The following is a description of a gene set: The directed movement of zinc (Zn II) ions into, out of or within a cell, or between cells, by means of some agent such as a transporter or pore. studied in species Homo sapiens Human Gene Set: GOBP_ZINC_ION_TRANSPORT, and this is the list of marker genes: TRPM2, SLC30A6, SLC30A10, SLC39A12, SLC11A2, SLC39A5, SLC30A1, SLC39A10, SLC30A3, SLC39A7, SLC39A1, AP3D1, SLC39A4, TMEM163, SLC30A8, MT3, TRPM3, SLC39A13, SLC30A9, SLC39A14, SLC30A7, SLC39A6, SLC1A1, TRPM7, SLC39A3, SLC39A9, SLC39A11, SLC30A4, SLC39A2, SLC30A2, SLC39A8, SLC30A5